The following is a description of a gene set: species: Mus musculus Genes predicted to be targets of miRBase v22 microRNA mmu_miR_3097_5p in miRDB v6.0 with MirTarget v4 prediction scores > 80 (high confidence targets). from publication Chen Y, Wang X (PMID 31504780) Mouse Gene Set: MIR_3097_5P, and this is the list of marker genes: Ganab, Sox9, Slc18a1, Ceacam18, Cspg4, Asxl1, Wtap, Kat6b, Zscan29, Zhx1, Taok1, Phyh, Hsdl1, Prune2 (prune homolog 2), Sipa1l2 (NCBI Gene Id 277957), Fap, Igf2bp2, Nsg2, Slc5a5, Dock9, Trip12, Emp2, Clmn, Pxt1, Zfp316, Utp20, Itga6, Ino80 (NCBI Gene Id 76476), Gpr15lg, Tsc22d1, D430041D05Rik, Pogk, Fnip1, Pcdh15, Tdpoz1, Vldlr, Siah2 (siah E3 ubiquitin protein ligase 2), Fgf13, Lce1g, Dock3, Apoa4, Slc35b4, Fsd1l, Mob3a, Lamp5 (lysosomal-associated membrane protein family, member 5), Ccdc38, Nfatc2, Cd38, Tmem41b, Shpk, Ubl3, Mapk10, Plpp1, Elf2, Hmx2, Bmf, F13b, Foxc1, Kctd1, Tmem132b, Mbnl2, Ghrl, Rnf146, Tnfaip8, Htatsf1, Col23a1, Nufip2, Adamts6 (ADAM metallopeptidase with thrombospondin type 1 motif 6), Trpm3, Nlk, Ttc8, Ipmk, Mrpl19, Unc119b, 4933421I07Rik, Carmil1, Ctdspl2, Gtf2h1, Scyl3